Given this list of marker genes Rps3, Setd7, Nudt16l1, Recql5, Shld2, C1qbp, Ogg1, Ubqln4, Parpbp, Hsf1, Klhl15 (kelch-like 15), Polq, Rif1, Ercc6, Shld3, Fbh1, Smchd1, Helb, Sgf29, Cyren, Shld1 (shieldin complex subunit 1), Csnk2a1, Mad2l2, Otub1, Rnf169, Plk1, Fancb, Kmt5a, Radx, Cgas, Abl1, Hmga2, Riox1, Kat5, Rmi2, Aunip, Trp53bp1, Twist1 (twist basic helix-loop-helix transcription factor 1), Mre11a, Senp3, here is a description of the gene set: Any process that stops, prevents, or reduces the frequency, rate or extent of DNA repair. species: Mus musculus Mouse Gene Set: GOBP_NEGATIVE_REGULATION_OF_DNA_REPAIR